The following is a description of a gene set: studied in species Mus musculus Any process that stops, prevents or reduces the frequency, rate or extent of relaxation of muscle. Mouse Gene Set: GOBP_NEGATIVE_REGULATION_OF_RELAXATION_OF_MUSCLE, and this is the list of marker genes: Pde4d, Neurog1, Grk2, Actn3, Tifab